The following is a description of a gene set: species: Mus musculus Mouse Gene Set: chr11A1, and this is the list of marker genes: Gas2l1, Camk2b, Gm24313, Mrps24, Drg1, Sec14l3, Ccdc201, Gm11975, Abca13, Rhbdd3, Gm11989, Gm12004 (predicted gene 12004), Hormad2, Zmat5, Gm11993, Cobl, Gm11992, Tns3, Snora5c, Wap, Patz1, Rps15a-ps6, Gm11983, Gm27393, Gm11984, Pes1, Adcy1, Myl7, Ccdc117, Eif4enif1, Osbp2, Znrf3, Gm24000, Lif, Gm22789, Gm12000, Eif3s6-ps1 (eukaryotic translation initiation factor 3, subunit 6, pseudogene 1), Sfi1, Nacad, Gm11999, Gm11970, Gm11946, Pla2g3, Nudcd3, Tbc1d10a, Igfbp1, Gm11973, Ube2d-ps (ubiquitin-conjugating enzyme E2D, pseudogene), Ascc2, Mir3060, Gal3st1, Urgcp, Fau-ps2, Gm11972, Gm11956, Ap1b1, Gm11978, Gm22156, Xbp1, Mir7651, 4930512M02Rik, Tbrg4, Mtfp1, Gm11967, Gm12599, Gm11981, Purb, Gm12002, Slc35e4, Pgam2, Nf2, Dusp18, Gm24013, Smtn, Dbnl, Pkd1l1, Sf3a1, Inpp5j, Nipsnap1, Gm11959, Sec14l2, Vwc2, Fignl1, Gm30172, Gm26458, Gm11962, Ccm2, Ogdh, Gm11998, Tcn2, Gm11957, Gm24958, 8430429K09Rik, H2az2, Gm11977, 4921536K21Rik, Castor1, Npc1l1, Igfbp3, Gm11401, Gm24036, Ddx56, 1700042O10Rik, Selenom, Upp1, Aebp1, Tmed4, Ewsr1, Emid1, Gm11944, Rnf215, Gm11399, Gm25142, Gm16518 (predicted gene, 16518), Gm11400, Ppia, Gm11980, Morc2a, Myo1g, Thoc5, Gm12003, Rnf185, Ankrd48, Kremen1, Ddc, Gm11952, Gm11997, Gm11953, Gm11945, 4930556J24Rik, Mir6918, Tug1, Ikzf1, Gm11961, Cabp7, Snhg15, Gm25058, Snora9, Gm11954, Uqcr10, Gck, Gm11996, Gm11950, Rasl10a, Grb10, Ramp3, Nefh, Gm12592, Mtmr3, Gm11951, AA413626, Gm11971, Sec14l4, Gm11958, Ykt6, Gm11964, Spmip7 (NCBI Gene Id 73862), Zpbp, Gm22471, Polm, Gm11990 (predicted gene 11990), Osm, Ccdc157, Zmiz2, Pik3ip1, Gm12598, Gm11949, Pisd-ps1, Gm11960, Hus1, Pold2, Limk2, Sun3